Given this list of marker genes PCGF2, OSER1, RELA, FABP1, AQP1, PLEKHA1, MAP3K5 (NCBI Gene Id 4217), PDGFD, AIFM1, GPX1, MIR107, KPNA4, HBB, MYB, CBX8, PPP2CB, TRPA1, BAK1, SRC, CRYAA, RPS3 (ribosomal protein S3), CFL1, CRK, KLF2, FCHSD1, PRKAA1 (protein kinase AMP-activated catalytic subunit alpha 1), HP, CDK1, PCNA, PPEF2, EEF2, TOP2B, CAPN2 (NCBI Gene Id 824), MMP2, RIPK1, ADAM9, ECT2, SPHK1, ERN1, IL18RAP, HBA2, HSF1, TXN, TXNIP, NET1, SOD2, NR4A3, DUSP1 (NCBI Gene Id 1843), CAT, BECN1, CRYAB, ABCC9, HBA1, ANKZF1, GATA5, SETX, PARK7, MAP1LC3A, CYP1B1, MIR103A1, CASP3, PPP5C, MAPK13, CDKN2A, PPP1R15B, MAPK7 (mitogen-activated protein kinase 7), FYN, COL1A1, SOD1, RIPK3, EZH2, IL18BP, KDM6B, HDAC2, MDM2, IL6 (NCBI Gene Id 3569), ABL1, TRPC6, SMPD3, HMOX1, TNFAIP3, BCL2, FXN, KCNA5, EDN1, NPPA, ZNF580, BNIP3, MT-ND5, PRKCD, SIRT1, AREG, LCN2, ZNF277, KLF4, SIRPA, PRDX3, HDAC6, NFE2L2, STAT1, RHOB, PPIF, TRPM2, here is a description of the gene set: species: Homo sapiens Any process that results in a change in state or activity of a cell or an organism (in terms of movement, secretion, enzyme production, gene expression, etc.) as a result of a hydrogen peroxide (H2O2) stimulus. Human Gene Set: GOBP_RESPONSE_TO_HYDROGEN_PEROXIDE